The following is a description of a gene set: EPHB-mediated forward signaling species: Homo sapiens Human Gene Set: REACTOME_EPHB_MEDIATED_FORWARD_SIGNALING, and this is the list of marker genes: EFNB1, ARPC1B, GRIN2B, PAK1, EPHB6, HRAS, LIMK1, FYN, CFL1, KALRN, EPHB1, ACTR3, ITSN1, SDC2 (syndecan 2), ARPC4, GRIN1, YES1, ARPC2, ARPC5, ROCK1, EPHB2, SRC, CDC42, ACTB, ROCK2, RASA1, EPHB3, EPHB4, ACTG1, WASL (NCBI Gene Id 8976), EFNB3, TIAM1, RHOA, RAC1, ARHGEF28, EFNB2, ACTR2, PTK2, ARPC3, LIMK2, LYN, ARPC1A